The following is a description of a gene set: studied in species Mus musculus Mouse Gene Set: REACTOME_O_GLYCOSYLATION_OF_TSR_DOMAIN_CONTAINING_PROTEINS O-glycosylation of TSR domain-containing proteins, and this is the list of marker genes: Adamts3, Adamts20, Sbspon, Sspo, Adamts9, Thsd1, B3glct, Sema5b, Thbs2, Adamts15, Pofut2 (protein O-fucosyltransferase 2), Adamts5, Adamts2, Adamts4, Adamtsl5 (NCBI Gene Id 66548), Cfp, Spon1 (NCBI Gene Id 233744), Adamtsl3 (NCBI Gene Id 77909), Thsd4, Adamts8, Adamts17, Thsd7b, Thbs1, Adamts16, Adamts6, Sema5a, Adamts7, Adamtsl1, Spon2, Adamtsl4, Adamtsl2, Adamts14, Adamts19, Adamts18, Thsd7a, Adamts10, Adamts12, Adamts1, Adamts13